Given this list of marker genes SCARF2, COL11A1, GNPNAT1, TCF4, SMARCA2, RPS15A, RYR3, WDR26, PORCN, BCR, FMR1, FANCF, SMARCB1, PDE3A, YY1AP1, OBSL1, NEPRO, HUWE1, IGF2, PIGB (NCBI Gene Id 9488), DPH2, NOG, NSDHL, RAD51C, CHN1, SNORD115-1, NEK1, FBXL3, DOCK6 (NCBI Gene Id 57572), PPP2R3C, KMT2D, INPPL1 (NCBI Gene Id 3636), KDM5C, GPC3, FANCB, NOTCH1, PRKACB, FZD2, COL3A1, SNRPB, RBM10, ARX (NCBI Gene Id 619216), HHAT, DPM1, SLC32A1, RPS26, GNPAT (NCBI Gene Id 8443), ZNF699, CCN2, PGAP3, GNAO1, IRX5, BRD4 (NCBI Gene Id 90616), NIPBL, CLDN16, KCNA1, LTBP3, USP9X, SMARCA4, INTU, ALMS1 (NCBI Gene Id 7840), SMARCE1, GNB2, SMARCD1, TBX4, USP7, EOGT, REV3L, SMAD4, PTH1R, GPC6, SETBP1, NELFA, SMARCC2, KIF22, RPS17, CEP152, DYNC2H1, SOX9, MAP3K7, FRAS1, ZMPSTE24, WDR19, SHH, GPX4, TRPM3, KIF15, RNU4ATAC, MMP9, PCGF2, SHOX, PEX7, CHUK, DNA2, PALB2, ZIC3, COL9A1, NHS, TNNI2, TBX3, PDGFRB, FTSJ1, SOX4, RPL26, CNOT3, BRCA2, RPL27, IFT52, KIF21A, TRIM8, PCYT1A, CHSY1, AHDC1, CDKL5, PEX5, RPL10, IFT57, CUL7, LMNB2, ERF, TUBB2B, MIR17HG, BPNT2, GMNN, MTFMT, SOX11, FGFRL1, DYNC2LI1, ERCC4, PTDSS1, HMGA2, SCUBE3, DNMT3A, TP63, BPTF, FBXO28, GNAS, COL11A2, MAPK1, HDAC4, EP300, IFT122, OFD1, ZMIZ1, CDC42BPB, GRIN1, FANCE, POU1F1, FANCL, GDF5, RTL1, EIF4A2, SIM1, PRKACA, CBFB, RAB23, MSL3, CTSK, RMRP, EXOC6B, XYLT1, RPL5, RPS29, TRPV4, P3H1 (prolyl 3-hydroxylase 1), CENPE, SRCAP, GNPTAB, KIF5C, RFWD3 (NCBI Gene Id 55159), ALG12, UNC80, TCTN3, ZBTB20, FANCM, CPLX1, DLK1, COL10A1, MIR140 (microRNA 140), RPS7, FGFR2, COL9A3, ARHGAP31, NGLY1 (N-glycanase 1), RSPO2, ADAMTSL2, DYNC2I2, ACAN, TUBB3, GRM7, LMBR1, BMP2, TRIO, HEATR3, RB1, B2M, SNIP1, BRF1, ASAH1, AP1G1, ABCA12, PKDCC, MCTP2, RNF2, OCA2, TNNT3, SNRPN, PWRN1, CWC27 (CWC27 spliceosome associated cyclophilin), NPAP1, MBD5, BCOR, PIK3CD, TBC1D24, SEM1, NSUN2, HOXD13, HYLS1, LIG4, DVL3, WRN, MKRN3, MGP, ARID1A, TAF6, NTNG1, BICRA, FANCD2, TPM2, WDR35, FBXO11, ASXL2, DPH1, MAGEL2, CCDC22, FANCI, PPM1D, PIGT, COMP, ORC1, SIN3A, ROR2, FGF16, FAM50A, PHOX2A, KIFBP, LONP1, EXTL3, EXT2, MAFB, CHRNA1 (cholinergic receptor nicotinic alpha 1 subunit), ACBD6, COG1, TRIP11, CACNA2D1, POC1A, DLX6, SMOC1, DDR2, MATN3, DONSON, ATP7A, IHH, EVC2, SLC26A2, RPL11, IGF1R, TBL1XR1, CTCF, ALG6, PSMD12, IFT140, SLC25A24, PIGW, EIF2AK3, GGCX, VPS35L (NCBI Gene Id 57020), PNKP, PRMT7, CD96, WNT3, MASP1, GATA1, SPECC1L, ALG13, PRKAR1A, ACVR1, PWAR1, ACTL6B (NCBI Gene Id 51412), RPL9, LAMA5, CASK, IKBKG, CLCN7, VAC14, SCN1B, PIK3C2A, APC, EDA, IFT43 (intraflagellar transport 43), KCNJ5, CREBBP, ATR, STX16, ADAMTS10, NOTCH2, FLNA, CHD6, SLCO2A1, RPS27, MTHFS, LAS1L, FGFR3, FANCA, RAB3GAP2, RPL35, PIGP, CAMK2G, CHD7, PIGS, LHX4, PITX1, DMXL2, CANT1, SIK1, WIPI2, DHODH, RAD51, MED12, JAG1, TRPS1, ALOXE3, EDA2R, PRIM1, PTCH1, STAMBP, NANS, WDR81, PRKG2, ALOX12B, RAC1, CRKL, SH3PXD2B, AIFM1, KCNN3, FLNB, HTT, FANCG, CHRND, ARID2, GJA8, PDE4D, KCNJ8, CHST11, RAB33B, FANCC, DYNC1H1, HERC2, RPS20, CNOT2, RAD21, PIGG, DVL1 (NCBI Gene Id 348497), DYNC2I1, GALNT2, RPL15, NDN, GNAS-AS1, NEUROD2, DPF2, CCDC8, HNRNPR, COL9A2, GSC, ANAPC1, RBBP8, ALDH18A1 (NCBI Gene Id 9193), KNSTRN, FGFR1, NIN, GJA5, TUBA1A, CRIPT, MYSM1, KDM6A, ASPH, MAD2L2, FGD1, BHLHA9, ROBO1, MEG3, DCHS1, ARSL, SLC35C1 (solute carrier family 35 member C1), HDAC6, PUM1, COX4I1, PGAP2, WNT5A, NFIX, SMC1A, TGDS, RPL35A, TBX5, PIGL (NCBI Gene Id 9487), CRLF1, LTBP2, FAT4, WAC, ADNP, GLI1, HPGD, GABBR2, SCN2A, BMP4, NPR2, COL2A1, COL25A1, MACROH2A1, ACP5, TELO2, MAPK8IP3, RAI1, ERI1, SLX4, RSPRY1, LHX3, PIGA, DLL4, MEGF8, ESCO2, CDK10, PTHLH, SEMA5A, SRY, EPS15L1, POLA1, SUCLG1, COG4, CTNND2, ADAMTS17, NSD2, KAT6B, CDKN1C, WNT7A, CDH11, MECP2, PLAG1, B3GALT6, TBCE, DYM, TMEM53, RPS6KA3, EVC, WNT10B, HDAC8, HOXA13, SATB2, MEIS2, AGPS, ZMYM2, HESX1, FKBP10, IFT81, LRP4, POLR3A, LETM1, RPS28, RIPK4, RPS10, LMNA, FERMT1, GPC4, EN1, CUL4B, GJA1, LBR, RPS19, CHST3, ARID1B, MRPS28, FIG4, ADA2, SLC25A22, TSR2, SVBP, PIGO, DLX5, MAPRE2, RPL8, CRELD1, RPL31, CUL3, SLC39A13, DHCR7, KLHL15, ANTXR2, RPS24, IFT80, CCBE1, KCNH1, PIGN, CHRNG, PIK3R1, KMT2A, CTBP1, KDM4B, PIGV, FN1, KRAS, SIL1 (SIL1 nucleotide exchange factor), MTOR, NALCN (sodium leak channel, non-selective), SALL4, TGFB1, TWIST1, MYCN, ASCC3, AFF4, TONSL, VPS13B, MYH3, PIGY (NCBI Gene Id 84992), ANKRD11, SMC3 (structural maintenance of chromosomes 3), EXT1, KDM1A, FBXW4, SATB1, PCNT, CAMTA1, TFAP2A, PIGF, MMP13, CCNQ, PUF60, BMPR1B, RUNX2, PHYH, SLC6A17, RPL18, BRCA1, BGN, BTRC, FGF9, RECQL4, TNFRSF11B, PLXND1, SF3B4, EIF4A3, ABCC9, PPOX, POR, B3GLCT, PIGQ, RBM8A, GLI3, CSGALNACT1, RBPJ, TFAP2B, XRCC2, PHF6, SNORD116-1, FGF10, PROP1, NXN, KIAA0753, MECOM, TWIST2, BRIP1, FBN1, KCNJ2, UBE2T, ATP6V1B2, SON, here is a description of the gene set: Aplasia/hypoplasia involving bones of the upper limbs species: Homo sapiens Absence (due to failure to form) or underdevelopment of the bones of the upper limbs. Human Gene Set: HP_APLASIA_HYPOPLASIA_INVOLVING_BONES_OF_THE_UPPER_LIMBS